The following is a description of a gene set: part of: Autophagy studied in species Homo sapiens Macroautophagy (hereafter referred to as autophagy) acts as a buffer against starvation by liberating building materials and energy sources from cellular components. It has additional roles in embryonic development, removal of apoptotic cells or organelles, antigen presentation, protection against toxins and as a degradation route for aggregate-prone proteins and infectious agents. The dysregulation of autophagy is involved in several human diseases, for example, Crohn's disease, cancer and neurodegeneration.<br>Autophagy is highly conserved from yeast to humans; much of the machinery was first identified in yeast (see Klionsky et al. 2011). Initially, double-membraned cup-shaped structures called the isolation membrane or phagophore engulf portions of cytoplasm. The membranes fuse to form the autophagosome. In yeast cells, autophagosomes are formed at the phagophore assembly site (PAS) next to the vacuole. In mammals, autophagosomes appear throughout the cytoplasm then move along microtubules towards the microtubule-organising centre. This transport requires microtubules and the function of dynein motor proteins; depolymerization of microtubules or inhibition of dynein-dependent transport results in inhibition of autophagy. Autophagosomes fuse with lysosomes forming autolysosomes whose contents are degraded by lysosomal hydrolases.<br><br>The origins of the autophagosomal membrane and the incorporation of existing membrane material have been extensively debated. The endoplasmic reticulum (ER), mitochondria, mitochondria-associated ER membranes (MAMs), the Golgi, the plasma membrane and recycling endosomes have all been implicated in the nucleation of the isolation membrane and subsequent growth of the membrane. Recently 3D tomographic imaging of isolation membranes has shown the cup-shaped isolation membrane tightly sandwiched between two sheets of ER and physically connected to the ER through a narrow membrane tube. This suggests that isolation membrane formation and elongation are guided by adjacent ER sheets, supporting the now prevalent 'ER cradle' model, which suggests that the isolation membrane arises from the ER.<br><br>Autophagy is tightly regulated. The induction of autophagy in response to starvation is partly mediated by inactivation of the mammalian target of rapamycin (mTOR) (Noda & Ohsumi 1998) and activation of Jun N-terminal kinase (JNK), while energy loss induces autophagy by activation of AMP kinase (AMPK). Other pathways regulating autophagy are regulated by calcium, cyclic AMP, calpains and the inositol trisphosphate (IP3) receptor. <br><br>In mammals, two complexes cooperatively produce the isolation membrane. The ULK complex consists of ULK1/2, ATG13, (FIP200) and ATG101. The PIK3C3-containing Beclin-1 complex consists of PIK3C3 (Vps34), BECN1 (Beclin-1, Atg6), PIK3R4 (p150, Vps15) and ATG14 (Barkor). A similar complex where ATG14 is replaced by UVRAG functions later in autophagosome maturation and endocytic traffic. Binding of KIAA0226 to this complex negatively regulates the maturation process. The ULK and Beclin-1 complexes are recruited to specific autophagosome nucleation regions where they stimulate phosphatidylinositol-3-phosphate (PI3P) production and facilitate the elongation and initial membrane curvature of the phagophore membrane (Carlsson & Simonsen 2015).<br><br>The ULK complex is considered the most upstream component of the mammalian autophagy pathway (Itakura & Mizushima 2010), acting as an integrator of the autophagy signals downstream of mTORC1. It is not fully understood how ULK1 is modulated in response to environmental cues. Phosphorylation plays an essential role (Dunlop & Tee 2013) but it is not clear how phosphorylation regulates ULK1 activities. ULK1 kinase activity is required for autophagy, but the substrate(s) of ULK1 that mediate its autophagic function are not certain. ULK1 may also have kinase-independent functions in autophagy. <br><br> PIK3C3 (Vps34) is a class III phosphatidylinositol 3-kinase that produces PI3P. It is essential for the early stages of autophagy and colocalizes strongly with early autophagosome markers. BECN1 binds several further proteins that affect autophagosome formation. Partners that induce autophagy include AMBRA1, UVRAG and SH3GLB1. Binding of BCL2 or BCL2L1 (Bcl-xL) inhibit autophagy. The inositol 1,4,5-trisphosphate receptor complex that binds BCL2 also interacts with BECN1, inhibiting autophagy. CISD2 (Nutrient-deprivation autophagy factor-1, NAF1), a component in the IP3R complex, interacts with BCL2 at the ER and stabilizes the BCL2-BECN1 interaction. Starvation leads to activation of c-Jun NH2-terminal kinase-1 (JNK1), which results in the phosphorylation of BCL2 and BCL2L1, which release their binding to BECN1 and thus induces autophagosome formation. <br><br>AMBRA1 can simultaneously bind dynein and the Beclin-1 complex. During nutrient starvation, AMBRA1 is phosphorylated in a ULK1-dependent manner (Di Bartolomeo et al. 2010). This phosphorylation releases AMBRA1-associated Beclin-1 complexes from dynein and the microtubule network, freeing the complex to translocate to autophagy initiation sites (Di Bartolomeo et al. 2010). <br><br>A characteristic of this early phase of autophagosome formation is the formation of PI3P-enriched ER-associated structures called omegasomes or cradles. Omegasomes appear to concentrate at or near the connected mitochondria-associated ER membrane. However, the phagophore also can incorporate existing material from other membrane sources such as ER exit sites (ERES), the ER-Golgi intermediate compartment (ERGIC), the Golgi, the plasma membrane and recycling endosomes (Carlsson & Simonsen 2015). Omegasomes lead to the formation of the isolation membrane or phagophore, which is thought to form de novo by an unknown mechanism (Simonsen & Stenmark 2008, Roberts & Ktistakis 2013). Phagophore expansion is probably mediated by membrane uptake from endomembranes and semi-autonomous organelles.<br><br>ATG9 is a direct target of ULK1. In nutrient-rich conditions mammalian ATG9 is localized to the trans-Golgi network and endosomes (including early, late and recycling endosomes), whereas under starvation conditions it is localized to autophagosomes, in a process that is dependent on ULK1. ATG9 is believed to play a role in the delivery of vesicles derived from existing membranes to the expanding phagophore. Yeast Atg9 forms a complex with Atg2 and Atg18. <br><br>PI3P produced at the initiation site is sensed by WIPI2b, the mammalian homologue of Atg18. WIPI2b then recruits Atg16L1. There are four WIPI proteins in mammalian cells. They are all likely bind PI3P and be recruited to membranes but the function of WIPI1, 3 and 4 in autophagy is not yet clear. WIPI4 (WDR45) has been shown to bind Atg2 and to be involved in lipid droplet formation; mutations in WIPI4 have been shown to cause a neurodegenerative disease.<br><br>The elongation of the membrane that will become the autophagosome is regulated by two ubiquitination-like reactions. First, the ubiquitin-like molecule ATG12 is conjugated to ATG5 by ATG7, which acts as an E1-like activating enzyme, and ATG10, which has a role similar to an E2 ubiquitin-conjugating enzyme. The ATG5:ATG12 complex then interacts non-covalently with ATG16L1. This complex associates with the forming autophagosome but dissociates from completed autophagosomes (Geng & Klionski 2008). The second ubiquitin-like reaction involves the conjugation of ubiquitin-like molecules of the LC3 family. LC3 proteins are conjugated through their C-terminal glycine residues with PE by the E1-like ATG7 and E2-like ATG3. This allows LC3 proteins to associate with the autophagosome membrane. <br><br>The ATG12:ATG5:ATG16L1 complex acts as an E3 like enzyme for the conjugation of LC3 family proteins (mammalian homologues of yeast Atg8) to phosphatidylethanolamine (PE). LC3 PE can be deconjugated by the protease ATG4. ATG4 is also responsible for priming LC3 proteins by cleaving the C terminus to expose a glycine residue. LC3 proteins remain associated with autophagosomes until they fuse with lysosomes. The LC3-like proteins inside the resulting autolysosomes are degraded, while those on the cytoplasmic surface are delipidated and recycled. ATG5:ATG12:ATG16L1-positive LC3-negative vesicles represent pre-autophagosomal structures (pre-phagophores and possibly early phagophores), ATG5:ATG12:ATG16L1-positive LC3-positive structures can be considered to be phagophores, and ATG5:ATG12:ATG16L1-negative LC3-positive vesicles can be regarded as mature autophagosomes.<br><br>Phagophore expansion is probably mediated by membrane uptake from endomembranes as well as from semiautonomous organelles.<br><br>The mechanisms involved in the closure of the phagophore membrane are poorly understood. As the phagophore is a double-membraned structure, its closure involves the fusion of a narrow opening, a process that is distinct from other membrane fusion events (Carlsson & Simonsen 2015). The topology of the phagophore is similar to that of cytokinesis, viral budding or multivesicular body (MVB) formation. These processes rely on the Endosomal Sorting Complex Required for Transport (ESCRT). ESCRT and associated proteins facilitate membrane budding away from the cytosol and subsequent cleavage of the bud neck (Hurley & Hanson 2010). Several studies have shown that depletion of ESCRT subunits or the regulatory ATPase Vps4 causes an accumulation of autophagosomes but it is not clear whether ESCRTs are required for autophagosome closure or for autophagosome to endosome fusion. UVRAG is also involved in the maturation step, recruiting proteins that bring about membrane fusion such as the class C Vps proteins, which activate Rab7 thereby promoting fusion with late endosomes and lysosomes. Reactome Pathway: Macroautophagy, and this is the list of marker genes: PIK3C3, MFN1, TUBA3C, FUNDC1, ATG9A, CSNK2A2, VDAC2, ATG4D, PLIN2, UBE2L3 (NCBI Gene Id 7332), DYNC1LI1, RRAGD, MAP1LC3C, PRKAG1, GABARAPL3, CETN1, GABARAPL2, USP30, IFT88, DYNC1H1, WIPI2, TUBB4A, UBE2D2, PARK7, VDAC3, ATG16L1, TUBAL3, WDR45, LAMTOR2, CHMP3, TUBA3D, ATG4C, HSF1, PRKAG3, UBE2N, VDAC1, TUBB4B, LAMTOR3, HSP90AA1, PRKN, MLST8, SQSTM1, CHMP4C, UBE2V1, DYNLL1, ATG14, CHMP2A, PEX5, TOMM70, ATG16L2, PIK3R4, TUBB2A (NCBI Gene Id 92919), TUBA8, HSPA8, UBC, ATG9B, TUBA4B, CHMP4B, ATG4B, UVRAG, TOMM5, PLIN3, ATG3, TUBB8, MAP1LC3A, RRAGA, PCNT, MTERF3, TSC2 (NCBI Gene Id 7249), LAMTOR1, UBE2D3, TOMM22, TOMM7, TOMM20 (translocase of outer mitochondrial membrane 20), VCP, ULK1, RRAGC, CHMP4A, ATG4A, RRAGB, TBK1, PRKAG2, ATG13, PRKAA1, SRC, HDAC6, TUBA3E, WDR45B, CSNK2B, PRKAA2, TUBB1, MTMR3, TUBA1C, UBA52, ATG7, ATG101, SLC38A9, MTOR, ATM, DYNC1LI2, RB1CC1, CHMP6, ATG5 (NCBI Gene Id 9474), PGAM5, TUBA1A, DYNC1I2, PRKAB1, WIPI1, DYNLL2, NBR1, TOMM6, PRKAB2, TUBB8B, CHMP2B, RPTOR, LAMTOR5, MAP1LC3B, TSC1, PINK1, TOMM40, TUBB6, DYNC1I1, ATG10, OPTN, MFN2, CHMP7, AMBRA1, CFTR, TUBA1B, CSNK2A1, EPAS1, UBB, TUBB2B, GABARAP, ATG12, BECN1, TUBB3, GABARAPL1, RPS27A, VIM, RHEB, ARL13B, LAMTOR4, MTMR14, TUBA4A